Given this list of marker genes LPCAT4, GNPAT, CHAT, LPCAT1, IFNB1, LPCAT2, NAT2, CRAT, CASD1, here is a description of the gene set: Human Gene Set: GOMF_O_ACETYLTRANSFERASE_ACTIVITY Catalysis of the transfer of an acetyl group to an oxygen atom on the acceptor molecule. species: Homo sapiens